Given this list of marker genes Snn, St8sia6, Cflar, Cfp, Ankrd6, Bcl2l2, Dhtkd1, Ankib1, Csf2rb2, Ro60, Sirt1, Lhfpl2, 9030624G23Rik, Kcnj6, Pou2f1, Mbnl1, Ptprc, Pik3r3, Jtb, Sec22a, Katnal2, Nrg3, Sra1, Myl1, Tgm4, Dnajc30, Frmd5, here is a description of the gene set: species: Mus musculus Mouse Gene Set: MIR_5135 from publication Chen Y, Wang X (PMID 31504780) Genes predicted to be targets of miRBase v22 microRNA mmu_miR_5135 in miRDB v6.0 with MirTarget v4 prediction scores > 80 (high confidence targets).